The following is a description of a gene set: Reactome Pathway: G1/S DNA Damage Checkpoints species: Mus musculus This event has been computationally inferred from an event that has been demonstrated in another species.<p>The inference is based on the homology mapping from PANTHER. Briefly, reactions for which all involved PhysicalEntities (in input, output and catalyst) have a mapped orthologue/paralogue (for complexes at least 75% of components must have a mapping) are inferred to the other species. part of: Cell Cycle Checkpoints electronically inferred by orthology from the curated human pathway, and this is the list of marker genes: Csnk1e, Cul1, Zfp385a, Phf20, Psmb5, Ubb, Psma7, Psmd12, Psmc5, Psmb4, Psma3, Chek2, Psmd13, Psmc4, Psma1, Psmb7, Mapk11, Psmd1, Psma6, Psmd6, Ccne2, Psmc6, Psma5, Cdkn1b, Nek11, Psmd7, Ccna1, Psmc1, Psma2, Ccne1 (cyclin E1), Psma4 (proteasome subunit alpha 4), Mapk14, Psmc2, Cdkn1a, Psmb6, Psmc3, Csnk1a1, Rps27a, Trp53